The following is a description of a gene set: Mouse Gene Set: GOBP_ICOSANOID_METABOLIC_PROCESS studied in species Mus musculus The chemical reactions and pathways involving icosanoids, any of a group of C20 polyunsaturated fatty acids., and this is the list of marker genes: Mif, Ces2f, Cyp4a29, Gstp2, Daglb, Cyp2u1, Tbxas1, Pla2g3, Ptgds, Gstm3, Ptgs2, Edn1, Ces2b, Hpgds, Dpep2, Ptges2, Gpx1, Cyp2j8, Cyp2j6, Alox8 (NCBI Gene Id 11688), Pla2g5, Cyp2f2, Pla2g2a, Cyp2j13, Ptges3-ps, Cyp2c38, Ces2h, Cyp2c40, Ggt5, Cyp4a14, Gstp-ps (glutathione S-transferase, pi, pseudogene), Sirt1, Syk, Tnfrsf1a, Gpx4, Plaa, Ephx1, Cyp2d11, Abcc10, Pla2g2f, Hpgd, Acox1 (acyl-Coenzyme A oxidase 1, palmitoyl), Akr1c21, Cyp4f13, Cyp2j12, Cyp2a4, Prxl2b, Cyp4a10, Akr1cl, Cyp2d9, Mgst3, Avp, Ptges, Cyp4a12a, Ptgr2, Pnpla8, Tlr4, Cd74, Cyp2j5, Cyp2e1 (NCBI Gene Id 13106), Mgst2, Mapk9, Aloxe3 (arachidonate lipoxygenase 3), Alox5, Cyp4f14, Cyp2c54, Alox5ap, Cyp2s1, Cyp2a22, Comt, Cyp2j11 (cytochrome P450, family 2, subfamily j, polypeptide 11), Edn2, Cyp4f18, Pibf1, Akr1c12, Pla2g10, Dagla, Akr1b7, Ptgis, Abcc1, Akr1c18, Fabp5, Cyp2b23, Cyp2j9 (NCBI Gene Id 74519), Cyp2c39, Ptges3, Pla2g4a, Tlr2, Avpr1a, Pdpn, Cyp2g1, Cyp2d22, Akr1b1, Anxa1, Akr1c13, Gsta1, Cyp2d34, Ptgs1, Cyp2d12, Cyp4f40, Cyp2b9, Gstm1, Cyp2d26, Cyp2d10, Ltc4s, Fcer1a, Cyp2b13, Pla2g4f, Mgll, Cyp2b19, Gstm6, Gstp3, Alox12, Fads1, Cyp4a12b, Cyp4a31, Cyp2j7, Cyp2t4, Dpep1, Cthrc1, Cyp1a2, Ptgr1, Prg3, Sco1, Cyp2b10, Cyp2a5, Il1b, Akr1c20, Ces2c, Akr1c19, Cyp2a12, Cyp2c55, Cyp4a30b, Cyp1b1, Alox12b, Alox15, Sphk1, Ces2e, Ces2a, Cyp2c29, Alox12e, Akr1c6, Ncf1, Ahr, Cyp2c50, Cyp4a32, Akr1c14, Atp6v1b1, Cyp2c23, Ces2g, Cyp4f15, Cyp2c37, Gstp1, Lta4h